The following is a description of a gene set: Human Gene Set: MIR6076 Genes predicted to be targets of miRBase v22 microRNA hsa-miR-6076 in miRDB v6.0 with MirTarget v4 prediction scores > 80 (high confidence targets). from publication Chen Y, Wang X (PMID 31504780) studied in species Homo sapiens, and this is the list of marker genes: C4orf33, PCSK5, TSC22D2, ZNF138, USP9X, KLF7, SUSD5, SMG9, MYOT, SLC6A2, C5, MAP4K4, CPEB4, PXYLP1, PPP4R2, ETS1, EP300, HSD11B1, SLC4A7, PLS1 (plastin 1), AJUBA, ENAH, BBS12, PCDH7, RNF2, PIK3CA, WDFY3, STOX2, RNF6, CPNE5, SSBP2, RBFOX2, POC1B, LRRN4CL, E2F3 (E2F transcription factor 3), SEMA6D, EPB41L5, TMEM25, EID1, TCIM, CLMN, HNRNPA2B1, SRBD1, ASPH, SBNO1, BCL9, MYT1L, KLF6, DNAJB12, SCN8A, RNF144A